The following is a description of a gene set: Psychotic episodes Human Gene Set: HP_PSYCHOTIC_EPISODES studied in species Homo sapiens Periods of time during which an individual experiences significant disturbances in their thoughts, perceptions, emotions, and behavior, resulting in a loss of touch with reality. These episodes are hallmark features of psychotic disorders such as schizophrenia, schizoaffective disorder, and certain forms of bipolar disorder., and this is the list of marker genes: NR3C1, ATRX, USP8, BRAF, CDH23, KDM1A, USP48, HMBS, GNAS, ATP13A2, NAGS, ARMC5, SNORD118, TP53, PARK7, PITRM1, MTHFR, SLC7A7